The following is a description of a gene set: Neighborhood of USP5 studied in species Homo sapiens Neighborhood of USP5 ubiquitin specific peptidase 5 (isopeptidase T) in the MORF expression compendium Human Gene Set: MORF_USP5, and this is the list of marker genes: GPAA1, DRG1, CTDNEP1, PPP1R11, PHB1, BMS1 (BMS1 ribosome biogenesis factor), NUP188, PSMD3, ELK1, TOMM34, METAP1, EBP, GNL2, ILF2, PSMD2, HTATSF1 (NCBI Gene Id 27336), CNP, WDR18, ZPR1, AFG3L2, TFAP4, MTX1, XPO6, PSMB6, ENTREP3, OTUB1, CALM2, CS, RPA2, NAP1L4, TXLNA, RING1, EIF6, MFN2, DNAJC8, SNU13, AATF, KXD1, AGPAT1, NELFB, MEA1, PRKAG1, ESYT1, PWP1, STARD7, MRPL28, PARN, ILVBL, RTCB, USP5 (ubiquitin specific peptidase 5), POLR2A (RNA polymerase II subunit A), DDB1